The following is a description of a gene set: Mouse Gene Set: GOBP_CELLULAR_RESPONSE_TO_EXTERNAL_STIMULUS studied in species Mus musculus Any process that results in a change in state or activity of a cell (in terms of movement, secretion, enzyme production, gene expression, etc.) as a result of an external stimulus., and this is the list of marker genes: Mir1895, Mir5621, Gclc, Gsk3b, Cav1, Mapk3, Ednra, Slc38a2, Mir125b-1, Myd88, Piezo2, Bak1, Kcnj2, Mir665, Habp4, Fgf2, Itga2, Mir194-2, Mir1192 (NCBI Gene Id 100316672), Nos3, Mir143, Kcnk4, Chek1, Piezo1, Tnfsf14, Mir101b, Mir26a-2, Mag, Tmem150c, Atp1a2, Cd40, Slc2a1, Mir3092, Fadd, Ripor2 (NCBI Gene Id 76622), Il33, Ptpn11, Arhgdia, Mir208a, Aqp1, Cda, Map2k4, Atp1a1, Bag3, Mir691, Mir148b, Gadd45a, Cnn2, Tlr3, Scx, Bcl10, Egfr, Mir300, Mir5128, Wnt11, Mir376a, Akt1, Rac1, Plec, Nos1, Itgb3, Ltbr, Got1, Tlr4, Col1a1, Map3k14, Tlr8, Tgfb1, Bmp6, Mir652, Tlr7, Ankrd1, Tnfrsf1a, Mir92-2, Cradd, Pax2, Mir214, Mir3473c, Irf1, Mir695, Mir760, Ptger4, Mkx, Abcb1a, Mir410, Bnip3, F11r, Pde2a, Sox9, Tmem87a, Casp2 (NCBI Gene Id 12366), Bad, Mir495, Ptgs2, Mtpn, Dag1, Eng, Mir511, Gja1, Mir301, Mir154, Ctnnb1, Nfkb1, Il1b, Mir26a-1, Mir379